The following is a description of a gene set: Negative regulation of TCF-dependent signaling by DVL-interacting proteins studied in species Homo sapiens Human Gene Set: REACTOME_NEGATIVE_REGULATION_OF_TCF_DEPENDENT_SIGNALING_BY_DVL_INTERACTING_PROTEINS, and this is the list of marker genes: DVL1, CCDC88C, DVL3, CXXC4, DVL2